The following is a description of a gene set: Human Gene Set: GOBP_NUCLEOTIDE_BINDING_OLIGOMERIZATION_DOMAIN_CONTAINING_1_SIGNALING_PATHWAY The series of molecular signals initiated by the binding of a ligand (such as a bacterial peptidoglycan) to a cytoplasmic nucleotide-binding oligomerization domain containing 1 (NOD1) protein receptor, and ending with regulation of a downstream cellular process. studied in species Homo sapiens, and this is the list of marker genes: TNFAIP3, RIPK2, TLR4, NOD1, SLC46A2, XIAP, SLC15A4, NFKBIA